Given this list of marker genes NR4A2, QDPR, PAH, FTCD, GCH1, IMPDH2, SPR, PCBD1, PTS, here is a description of the gene set: Abnormal circulating phenylalanine concentration Human Gene Set: HP_ABNORMAL_CIRCULATING_PHENYLALANINE_CONCENTRATION studied in species Homo sapiens Any deviation from the normal concentration of phenylalanine in the blood circulation.